The following is a description of a gene set: species: Mus musculus part of: Metabolism of water-soluble vitamins and cofactors Reactome Pathway: Nicotinate metabolism electronically inferred by orthology from the curated human pathway This event has been computationally inferred from an event that has been demonstrated in another species.<p>The inference is based on the homology mapping from PANTHER. Briefly, reactions for which all involved PhysicalEntities (in input, output and catalyst) have a mapped orthologue/paralogue (for complexes at least 75% of components must have a mapping) are inferred to the other species., and this is the list of marker genes: Nnmt, Nadsyn1, Nmnat3, Slc22a13, Naprt, Qprt, Nmrk2, Nudt12, Naxd, Nmrk1, Naxe, Cd38, Slc5a8